Given this list of marker genes IKBKB, CREBBP (CREB binding protein), PAK1, SYK, PLCG2, KLRC4, CLEC6A, SRC, PAK2, PAK3, LYN, EP300, TRAF6, KLRD1, CLEC7A, KLRC1, KLRK1, MAP3K7, KLRC3, KLRC2, FYN, KLRC4-KLRK1, TYROBP, here is a description of the gene set: Human Gene Set: GOBP_RESPONSE_TO_LECTIN studied in species Homo sapiens Any process that results in a change in state or activity of a cell or an organism (in terms of movement, secretion, enzyme production, gene expression, etc.) as a result of a lectin stimulus. A lectin is a carbohydrate-binding protein, highly specific for binding sugar moieties.